Given this list of marker genes Rnd1, Klf4, Cavin3, Cdc42se1, Sat1, Vhl, Noct, Traf6, Pdpr, Higd1a, Map3k1, Dusp16, Jmjd6, Soat1, Sox2, Kif5a, Arl6ip5, Rps6kc1, Tgif1, Slc19a1, Zfp36, Tm4sf1, Il13ra1, Nfkbia, Gata3, Plpp3, Rps6ka5, Pfkfb3, Xpnpep1, Lrp5, Plk2, Ankrd1, Me2, Psmc4, Eno2, Mxi1, Scgb1b27, Mxd1, Selenbp1, Mapk6, Sdc4, Pgf, Pim3, Chic2, Arx, Rgs16, Rusc2, Tnc, Nedd4l, Nap1l1, Maged1, Ptger4, Slc37a4, Hk2, Afg3l2, Arhgap5, Atf3, Jag1, Csrnp1, Sgk1, Rbpj, P4ha1, Frmd6, Dusp4, Rcan1, Rngtt, Gzf1, Mertk, Anxa2, Ddx39b, Ccn1, Siah2, Pgam1, Vwa1, Dnajb4, Tpi1, Crtc3, Insig2, Appl2, Rcor1, Aimp2, Cyp21a1, Fos, Bcl10, Gprc5a (NCBI Gene Id 353241), Lhx9, Bnip3, Pgk1, Ccn2, Zfp330, Cyrib, Klf6, Cd44, Lxn, Nedd9, Mpp2, Gbe1, Spry4, Palld, Smox, Clcn5, Homer1, Cd93, Kctd11, Egr1, Wsb1 (NCBI Gene Id 78889), Cxcl1, Jmjd1c, Pprc1, Nagpa, Depp1, Srgn, Hbegf (NCBI Gene Id 225370), Prdx5, Ets1, Ptch1, Phlda1, Tnfrsf23, Cdc42ep3, Tcim, Atp7a, Pdk1, Angptl4, Edn1, Cnot7, Helt, Rora, Fam162a, Spry2, Nfkbiz, Aldh1l2, Slc2a1, Errfi1, Spast, Dusp14, Acap2, Vegfa, Rars1, Pnrc1, Ppp1r3b, Zbtb20, Hilpda, Ak4, Sertad2, Ndrg1, here is a description of the gene set: from publication Gross C, Dubois-Pot H, Wasylyk B (PMID 17704799) The ternary complex factor Net/Elk3 is downregulated in hypoxia and participates in the induction by hypoxia of several genes, including c-fos, vascular endothelial growth factor and egr-1. However, the global role of Net in hypoxia remains to be elucidated. We have identified, in a large-scale analysis of RNA expression using microarrays, more than genes that are regulated by Net in hypoxia. In order to gain insights into the role of Net in hypoxia, we have analysed in parallel the genes regulated by HIF-1alpha, the classical factor involved in the response to hypoxia. We identified about genes that are regulated by HIF-1alpha in hypoxia. Surprisingly, when we compare the genes induced by hypoxia that require either Net or HIF-1alpha, the majority are the same (75%), suggesting that the functions of both factors are closely linked. Interestingly, in hypoxia, Net regulates the expression of several genes known to control HIF-1alpha stability, including PHD2, PHD3 and Siah2, suggesting that Net regulates the stability of HIF-1alpha. We found that inhibition of Net by RNAi leads to decreased HIF-1alpha expression at the protein level in hypoxia. These results indicate that Net participates in the transcriptional response to hypoxia by regulation of HIF-1alpha protein stability. Mouse Gene Set: GROSS_HYPOXIA_VIA_ELK3_AND_HIF1A_UP Genes up-regulated in SEND cells (skin endothelium) at hypoxia after knockdown of ELK3 and HIF1A by RNAi. studied in species Mus musculus